Given this list of marker genes RRP12, ELK4, DYNLL2, NGLY1, KLK3, INSIG1, CAMKK2, ACSL3, TMEM50A, GNAI3, KLK2, HMGCR, MAP7, EVI5, BMPR1B, SPCS3, MED28, CENPN, UBE2J1, TRGC1, CRLS1, MMP16, FADS1, here is a description of the gene set: Progression of prostate cancer to androgen independence is suspected to involve the androgen and protein kinase A (PKA) signaling pathways. Here for the first time, the transcriptomes associated with each pathway and common transcriptional targets in response to stimulation of both pathways were identified in human prostate cancer cells using Affymetrix GeneChip technology (Human Genome U133 plus2). Statistically significant changes in the levels of genes in response to androgen and genes in response to activation of the PKA pathway were determined using GeneSpring software. Expression of a subset of these genes (22) that were transcriptional targets for the androgen and/or PKA pathways were validated by reverse transcriptase-polymerase chain reaction and Western blot analyses. Application of small interfering RNAs to the androgen receptor (AR) revealed that in addition to KLK3, levels of expression of KLK2 and SESN1 were regulated by AR activated by both the androgen and PKA signaling pathways. SESN1 was identified as a gene repressed by activated AR. These results provide a broad view of the effects of the androgen and PKA signaling pathways on the transcriptional program of prostate cancer cells and indicate that only a limited number of genes are targeted by cross-talk between AR and PKA pathways. Genes up-regulated in LNCaP cells (prostate cancer) treated with forskolin, an activator of PKA pathway. studied in species Homo sapiens Human Gene Set: WANG_RESPONSE_TO_FORSKOLIN_UP from publication Wang G, Jones SJ, Marra MA, Sadar MD (PMID 16751804)